The following is a description of a gene set: Human Gene Set: WP_PROXIMAL_TUBULE_TRANSPORT species: Homo sapiens Proximal tubule transport, and this is the list of marker genes: SLC3A1, SLC5A1, SLC7A9, AQP1, SLC3A2, SLC16A10, SLC22A7, SLC47A2, ATP6V1G1, SLC22A2, CA4, ATP6V1A, ATP6V1E1, SLC4A4, SLC13A3 (solute carrier family 13 member 3), ATP6V1B1, SLC5A5, SLC2A1, ATP6V0E1, ATP6V1H, ABCB1, SLC9A3, ABCC4, SLC4A2, ABCC2, ATP6V0D2, SLC34A1, ABCG2, SLC7A8, SLC36A2, SLC6A18, SLC6A19, SLC1A1, ATP1A1, ATP1B1, SLC5A2, SLC5A8, SLC22A11, CLTRN, SLC47A1, FXYD2, SLC12A4, SLC22A6, SLC22A8, CA2, ATP6V1F, ATP6V1C1, SLC34A3, SLC6A20, ATP6V0A4, SLC2A2, SLC26A6, ATP6V0C, SLC7A7, SLC20A2, ATP6V1D, ATP6V0B